Given this list of marker genes H2AZ2, FBN1, LTA, TAF15, SEC22A, NDUFA2, SNRNP200, GPX4, RAD21, RPN1, CCHCR1, SPAG5, PEX6, HK2, STK3, YBX1, TAX1BP3, PHYH, CMC4, IL21R, MACF1, RPL23, TMC6, F8A1, MYL6, H3-3A, ACYP1, UGT2B17, PPA2, FANCA, SART1 (spliceosome associated factor 1, recruiter of U4/U6.U5 tri-snRNP), ACTA2, PSMD4, SCLY, DPF2, ATP1A1, MAP4, TRIM33, PHKA2, SRF, LSM4, RPS7, HES1, TADA3, SRP19, RPL27A, TCF7, NDUFB8, CALM1, SMARCD2, CD2BP2, KHSRP, SLC39A7, CCR10, GLUD1, DBI, DECR2, APAF1, PPIB, ARHGDIB, SACS, MTA1, PEBP1, NDUFS8 (NCBI Gene Id 4728), TXN2, NDUFS6, VPS4A, IFNGR1, ACOT7, CEPT1, APBA3, DAZAP1, DNAJB5, RRP1, GTF2H3, CYP51A1, ZBED5, ARID3A, B3GAT3, NDUFB4, VPS11, PPAN, HSPA1A, GSDME, NENF, ATP5MC3, NCAPG, HNRNPU, GTF2F2 (NCBI Gene Id 2963, general transcription factor IIF subunit 2), ZNF330, SNAP29, UQCRQ, ZNF544, WWP2, SGTA, ENO3, EIF4EBP1, DMXL1, UCP2, ERCC5, ERG28, STIM1, CDK2AP2, UBE2C, SCAND1, CSK, GBA1, PCK2, HAGH, PMF1 (polyamine modulated factor 1), DPYSL2, PARP1, PKD1, SUPT5H, RALY, SPG7, TUBB2A, GNL2, TUBA1A (tubulin alpha 1a), PGAP2, GTF2I, UBL5, BLK, MYL6B, ARHGAP1, ADGRE5, CRCP, CDC42, NPC1, EP300, SUPT20H, COX4I1, FDPS, XRCC1, VDAC3, MBOAT7, NAGLU, B4GALT7, NUDT3, ZMYM2, HNRNPDL, CTTN, NACA, ETV5, RAB8A, PRIM2, ARID4B, RPS8, YARS2, ENOPH1, PGLS, EZH2, BAX, TRA2A, ZP3, PABPC3, DUS1L, TEX264, COX6C, RAB1B, ADA, BAZ1B, RHOA, NPM1, ATP5IF1 (NCBI Gene Id 93974), MEIS2, PRDX2, NUDT1, ZNF14, PEX14, PCDHGC3, FKBP3, ERCC1, CCNF, ARF1, RGS20, TOMM40, GMPS, ZNF212, POLE, RGS14, YBX3, AP1B1, IMPDH1, NDUFB11, DPAGT1, RPL39, ANKRD13C-DT, NET1, HMGCS1, TACC3, CLIP1, S100A11, MZF1, ATP5PF, NAP1L1, CEP43, TADA2A, HDGFL3, PKD2, MUTYH, PSMC3IP, FCER2, B2M (NCBI Gene Id 567), DROSHA, RPS25 (ribosomal protein S25), ANXA7, RBM39, EMD, PIAS4, HLA-DOB, GRK6 (G protein-coupled receptor kinase 6), MYO9A, EZR, PAIP1, PARK7, COX6A1, LDB1, LMO2, MAP2K2, GDI1, KCNK1, KIF22, GIPC1, RTN3, PTTG1, RAB5B, GALE, NFE2L1, ATP5F1D, RPS27L, CYB5R3, CFDP1, ARF5, RPS23, LUC7L, XRCC2, LCP2, RPL37, MBD3, ICAM3, MRM2 (NCBI Gene Id 29960), TUBB, CR2, MPST, NDUFB1, CD22, COPG1, DNASE1L2, PDCD5, IFI16, DDX3X, TROAP, TBCA, BRD8, SLC2A6, RPL36, DVL1, PKN1, C1QBP, CD74, UQCRC1, ATXN3, TCOF1, DCXR, NUTF2, NDUFS5, APEX2, KDM5C, KAT5, PFN1, DARS1, PIN1, STAT2 (NCBI Gene Id 6773), ATP5MF, TM6SF1, MARCKSL1, SNRPD1, HNRNPL, HSPA9, POLA2, FKBP2, AP3S2, TECR, CNPY3, LSS, ZNF84, LTB, MAP4K2, ATP8B1, IL27RA, GOLGA2, ATP5ME, OAZ1 (NCBI Gene Id 4946), MTHFS, B4GALT2, G3BP1, CKS2, NONO, PSME2, CSNK1E, TPP1, PTMA, HNRNPD, RPL37A, RPS6KB1, HERC2, CNPPD1, ACOT8, ELOB, ICMT, B4GALT1, NDUFV2, CHUK, ACY1, DNAJC8, TESK1, DDT, POLA1, ATP5MC2, HMBS, TGIF2, POLR2I, PIN4 (NCBI Gene Id 5303), PRRC2A, SERTAD3, CDK11B (cyclin dependent kinase 11B), SLC12A9, HSPB1, ZDHHC13, FARSA, CUL4A, CD70, MGAT3, VASP, MORF4L2, PQBP1, GCHFR (GTP cyclohydrolase I feedback regulator), ACOX1, POLG, RECQL4, PIGB, TERF2IP, BCAT2, RBBP4, CD19, GATB, RPS28, COX5B (NCBI Gene Id 1329), HNRNPA1, DHCR24, MLF2, AURKA, MSH5, FDXR, HNRNPA3P1, POLRMT, COX6B1, ERH, RRM1, RPL4, GTF3C1, RPLP2, RPL19, SOX12, NDUFA3 (NADH:ubiquinone oxidoreductase subunit A3), MRPL23, ACTL6A, IFNAR2, SMARCA4, NBAS, PTP4A1, HMGB1, GNL1, HTT, NME4, CHMP1A, ACTG1, DHCR7 (NCBI Gene Id 6589), HDAC1 (histone deacetylase 1), STT3A, KIF20A, CYB5B, TTF2, PNRC1, AHR, TAF5, CSTB, FXYD2, MAPK12, PSMB3, CENPI, STOML1, PSMB5, EIF4G3, NDUFA7, CDK5, CEBPB, PSMD13, RRP7A, DEAF1, FAU, TP53, HSD17B4, BLOC1S1, HMGN1, DNASE1L3, TRMT1L, DPM3 (NCBI Gene Id 54344), RREB1, CSNK1G2, PTPN7, SGPL1, NME2, APRT (adenine phosphoribosyltransferase), MEF2D, VRK1, ALDH6A1, ARPC4, AKR1A1, IVD (isovaleryl-CoA dehydrogenase), ZNF232, AHCY, SERF2, AUP1, RXRA, ENSA, NARF, HEXIM1, TCEA1, SPA17, GFER, TOP2A, DOK1, SAFB, CCND2, DDB2, GTF2H2, TLE5, HDAC2, NDUFB7 (NADH:ubiquinone oxidoreductase subunit B7), EBP, SRGN, GSS, TPP2 (tripeptidyl peptidase 2), NDC80, HMGB3, CACYBP (NCBI Gene Id 27101), CCDC85B, TCIRG1, TAF6, STXBP2, H2BC5, SRP14, SNRNP40, CENPF, NSDHL, CDC20, PTPN6, ROBO1, WRAP73, NDUFA1, PNPLA6, MEA1, NCOR1, HEBP2, NPIPB3, MAD1L1, SFN, RAP2B, RTN4, HMHB1, HNRNPA2B1, EPS15, TSPAN3, ORC6, CST3 (cystatin C), SF3A2, BANF1, VAMP2, DAPP1, TARBP1, SLC4A7, TUSC2, here is a description of the gene set: species: Homo sapiens from publication Spielman RS, Bastone LA, Burdick JT, Morley M, Ewens WJ, Cheung VG (PMID 17206142) Variation in DNA sequence contributes to individual differences in quantitative traits, but in humans the specific sequence variants are known for very few traits. We characterized variation in gene expression in cells from individuals belonging to three major population groups. This quantitative phenotype differs significantly between European-derived and Asian-derived populations for 1,097 of genes tested. For the phenotypes with the strongest evidence of cis determinants, most of the variation is due to allele frequency differences at cis-linked regulators. The results show that specific genetic variation among populations contributes appreciably to differences in gene expression phenotypes. Populations differ in prevalence of many complex genetic diseases, such as diabetes and cardiovascular disease. As some of these are probably influenced by the level of gene expression, our results suggest that allele frequency differences at regulatory polymorphisms also account for some population differences in prevalence of complex diseases. Genes up-regulated in lymphoblastoid cells from the European population compared to those from the Asian population. Human Gene Set: SPIELMAN_LYMPHOBLAST_EUROPEAN_VS_ASIAN_UP